The following is a description of a gene set: Human Gene Set: HP_VISUAL_ACUITY_TEST_ABNORMALITY Visual acuity test abnormality studied in species Homo sapiens, and this is the list of marker genes: TUBA1A, KIF21A, COL25A1, TERT, PDGFB, SMARCB1, POU3F4, BAP1, PIK3CA, DHX38, TUBB3, PHOX2A, APC, SMO, SMARCE1, SUFU, TUBB2B, LRP5, TRAF7, RPGRIP1, AKT1, NF2, C1QTNF5